The following is a description of a gene set: Genes predicted to be targets of miRBase v22 microRNA hsa-miR-511-3p in miRDB v6.0 with MirTarget v4 prediction scores > 80 (high confidence targets). species: Homo sapiens Human Gene Set: MIR511_3P from publication Chen Y, Wang X (PMID 31504780), and this is the list of marker genes: CPNE4, NLGN1, USP25, RNF138, KANSL1L, TMEM209, SCARA3, DCAF8L1, CCDC174, ZNF480, RAB44, HSPH1, ARL14EPL, SUOX, ZFP28, TMEM255A, SSBP2, ZNF626, AFDN, ADGRF5, MAN1C1, KPNA1, VMA21, NETO2, PANX3, ADH1B, ACBD5, PLAG1, RBP4, BCL2, AEBP2, SEMA3A, PUM1, STARD8, TOP2B, ZNF493, KCNMA1 (potassium calcium-activated channel subfamily M alpha 1), ZNF85, XKR6, RAB3C, ZNF486, KCNJ13, RBM5, UNC79, RICTOR, TDRKH, ZSCAN5B, FHL5, ZNF99 (zinc finger protein 99), ZNF254, FBXO30, ALG6, SLCO3A1 (NCBI Gene Id 28232), PURG, MDFIC, ANKRD44, FBXL3, ZNF257, PRDM4, GUCY1A2, CAMK2N1, IMMP2L, ZNF138, MORC1, PDE10A, ATP2A2, HOMER1, COBLL1, ZNF117, NOX4, FNDC3A, VPS13C, LSM8, HINT3, ZNF415, UBE2V2, ZFAND3, CRIM1, EDNRA, LAMP2, KCNJ3, CUBN, ZNF107, XRCC4, TNRC6B, PDZRN4, CTNND2, TSPAN12, RB1, OTULINL, NUDC, ZNF737, HNRNPA2B1, PAN3, SLC44A1, MATN3, TMEM229A, TNFRSF21, ENOSF1, CSRNP3, PLP1, GJB1, AMER2, TMEM41B, XKR4, ATP11C, ATXN7, DYDC2, INHBA, MALT1, MCUR1, MTRF1, DENND2C, SMAD9, ZNF730, LRRN3, ZNF354C, ZNF543, ZNF540, PGBD2, CRPPA, PATJ, AJAP1 (NCBI Gene Id 55966), BACH2, ARFGEF3, ZNF90 (NCBI Gene Id 7643), SH3TC2, SPRY2, LRRC31, SIRT3, LPP, SLC24A2, ADAMTS9, SORCS3, POLR3G, RNF213, GABRB3, KRBOX1, YPEL2, DENR, ABHD18, OMA1, RASSF5, SLC35E3, PLA2G12A, VENTX, NXPH1, MIS18BP1, LDLRAD2, PALLD, NUDT7, EGR3, IREB2 (NCBI Gene Id 3658), MATR3, ZNF253, ZNF449, CENPA, ZNF506, LRATD1, HEXIM1, DYNLT5, PLSCR4, ZNF124, ROCK2, ZNF676, ANGPTL2, TXLNB, FNIP2, GTPBP2, PRRG4